The following is a description of a gene set: Prolactin receptor signaling studied in species Mus musculus Mouse Gene Set: REACTOME_PROLACTIN_RECEPTOR_SIGNALING, and this is the list of marker genes: Ghr (growth hormone receptor), Sh2b1, Rbx1, Prl, Cul1, Gh, Skp1, Prlr (NCBI Gene Id 19117), Jak2